The following is a description of a gene set: Genes containing one or more binding sites for (Nfatc1) in their promoter regions (TSS -1000,+100 bp) as identified by GTRD version 20.06 ChIP-seq harmonization. species: Mus musculus from publication Yevshin I, Sharipov R, Kolmykov S, Kondrakhin Y, Kolpakov F (PMID 30445619) Mouse Gene Set: NFATC1_TARGET_GENES, and this is the list of marker genes: Hsp90aa1, Gm5960, Rpl28-ps4, Xirp1, Exoc5, Gm8609, Kcnab1, Sars2, Stard3, Slc26a8, Or3a1c (olfactory receptor family 3 subfamily A member 1C), Plxna4os1, 1700095J12Rik, Pank4, Cyb561, Dynlt3, 4930428N03Rik, Gm15941, Hps1, Rbm5, Gm11349, Igkv3-10, Huwe1, Tspan31, Cwc22, Tmtc2, Necab3, Or7g19, 1600029O15Rik, L1cam, Exosc3, AU019990, Lrig3, S100a4, Gm28888, Npc1, Lrrtm2, Ndufb2, Sclt1, Opn1sw, Spata6l, Ppp1r42, Peg12 (paternally expressed 12), Gm19028, Xkr6, Gm17087, Gm37548, BC050972, Skint3, Gm17227, Foxj3, Mir16-2, 2900064K03Rik, Vgll1, Gm29741, Slc7a15, Dmkn, Sesn2, Slit2, Spart, Crlf1, Adgrl4, F830212C03Rik (RIKEN cDNA F830212C03 gene), Gm17501, Mir500, Pkn2, Gm11869, Gzmk (NCBI Gene Id 14945), Dcp1b, Hspa8, Pgk1, Or4b13, Gm12153, Sp1, Rbm46os, Arhgap12, Phldb2, Tanc1, Vps25, Aoc1l1, Gm23241, Ltbp3, Ascc3, Stxbp4, Pacrg, Tcf12, Gm12295, Zscan2, Gm24965, Slc38a6, Tns3, Akr7a5, Sntn, Lrfn5, Gm22576, Mustn1, Arf4, Gnas, Rpl37rt, Orai2, Serpinb10, Ppa1, Dnajc11, Avl9, Ifngr1, Ndrg3, Dctn6, Prss59, Ubqlnl, Cerk, Fnbp1l, Nr1i2, Cfap126, Nsun4, Hk1, Lce1c, Cp, A4galt, Col17a1 (collagen, type XVII, alpha 1), Cfap74, Gpc1, Cast, Dnajc13, Mapk14, 4931429P17Rik, Gm16508, Adam33, C6, Inhba, Tafa3, Cfap221, Rhpn2, Hmgb1, Spsb4, Plekhg4, Mgat4d, Sys1, Plcl1, Spmip3, Vat1l, Or6d12, Fam107b, Nr4a2, Ppie, Cyp2j11, Pramel6, Fbxo30, Gm25697, Lztfl1, Sap30, Or9g3, Ocm, Ceacam1, Nptn, Ccdc33, Gm14401, Mannr, 5830437K03Rik, Ica1, Snx25, Adcy6, Kdm1b, Slc26a3, Slc32a1, Acot12, Ppp1r12b, Atp2b4, Kntc1, Cdkn1c, Igsf9, Chn1, Ppp1cc, Spaca1, Nup42 (nucleoporin 42), Tiam2, Acadm, Srr, Slco1a5, Efcab6, Gm22985, Gtf3c3, Gm33866, Gm15564, Btnl9, Snrpn, Pes1, B530045E10Rik, St7, Bach2it1 (NCBI Gene Id 102635275), Primpol, 0610043K17Rik, Or13j1, Gm10163, Trim72, Kif3b, Arhgef2, B430319H21Rik, Apbb2, Gpr161, Phxr4, Nsd2, Card10 (NCBI Gene Id 105844), Mir5130, Ptges, 2500002B13Rik, Sec16b, Lmbr1l, A930006K02Rik, H1f8, B4gat1, Znhit1, Lix1l, Cdkn2d, Gm17057, Gramd2b, Slc25a21, Pprc1, Il1rap, Gm14679, Dennd1a, Plec, Zbtb7b, Slc2a13, Fxyd5, Toe1, Usp53 (NCBI Gene Id 99526), Nat3, Gls, Or5ar1, Gm17473, Aldh1l2, Cdh8, Kpna6, H2-Ob (histocompatibility 2, O region beta locus), Slc2a9, Gm22863, Usp38, Rad52, Tchp, Mir15b, Kifc3, Uhmk1 (NCBI Gene Id 98572), AU015336 (NCBI Gene Id 106309), Myo1c, Ankrd34b, Gjb4, Or4d10, Trpc4ap, Gm13219, Gm9632, Stk11, Cpvl, Furin, Dgkd, 4930551E15Rik, Becn1, 1700039E22Rik, Dstn, Ssc5d, I0C0044D17Rik, Mical2, Grid2ip, Gm2451, Lemd1, Ahcyl1, Gm15511, Ptprc, Abl2, Gm11392, Ctsl, Fscn1, Slc25a3, Gm28809, Nkx2-9, Chac1, Tlcd1, Gem, Ctbp2, Or2w1b, Pira2-ps1, Gm11862, Elavl4, Dars2, Ctdsp1, Plekha4, Frg2f1, Ctnna3 (NCBI Gene Id 73853), Vcan, Atf6, Arhgap19, Lep, Sec61bl, Lrp2bp, Retsat, Btn1a1, Hectd2, Gm7289 (NCBI Gene Id 640234), Pus10, Unc13b, Gnpat, Ep300, Gm11266, 2010003K11Rik, Cpa6, Sec14l1, Gsk3b, Serpinb3d, Mir6236, Mir467c, Cd82, Gm23691, Cep250, Ccdc9, Rnpc3, Glt8d2, Nudcd2, Ric1 (RAB6A GEF complex partner 1), Klhdc8b, Rab40c, Esp4 (exocrine gland secreted peptide 4), Gm32460, Hnrnpl, Mrps12, Or1o3, Rasgrp3, Cntn4, Gm19705, Smim43, Adamts6, Tnfaip2, Taf3, Arhgdib, Egfl7, Vps4b, Tmprss11b (NCBI Gene Id 319875), Gm28863, Pid1, Eif3d, Gm23644, Gm11816, Retreg1, Gm26080 (predicted gene, 26080), Gm17450 (NCBI Gene Id 115488131), Zup1, Neat1, Satb1, Mef2d, Fut1 (fucosyltransferase 1), Daw1, Igfbp4, Cep104, Scn1a, Nek8, Hikeshi (NCBI Gene Id 67669), 1700047M11Rik, Cdkn2c, Bnip1, Anxa11, Gm25384, Col24a1, Or1j16, Esrrb, Mpzl1, Ginm1, Gm12002, Syne2, Fmc1, Aig1, Gm12795, Meaf6, Plekhn1, Shc1 (NCBI Gene Id 20416), Tesc, Spata31g1, Gm14921, Cnn3, Acox1, Myocd, Mir6349, Slc39a13, Zfp286os, Gcnt2, Slc5a7, Dnhd1, Nsun7, Gm16084, Gm37358, Sorbs1, Cntrob, Ttyh3, Cttnbp2, Gm53065, Elmo1, Or4k6, Cenpl, Or4e1, Inpp5a, Ifitm2, Cc2d1b, Actl7a, E330020D12Rik, Srl, Gm5082, Gm25408, Frem1, Commd8, Mir652, Gm10222, Fchsd1, Pla2g7 (phospholipase A2, group VII (platelet-activating factor acetylhydrolase, plasma)), Gm43391 (NCBI Gene Id 115490167), Krtap19-3, Or6c76, Jph4, Esco1, Ltbp4, Pde4d, Dnm3os, 1700064H15Rik, Gal3st1, Gm28818, S100a5 (S100 calcium binding protein A5), 4930555A03Rik, Abi1, Ift74, 2310081O03Rik, Or5an6, Clca3a2, Ampd2, Gm5860, Cep85, Mdm4 (NCBI Gene Id 98570), Itga4, Gcg, Polr2a (NCBI Gene Id 20020), Bbs7, E230016M11Rik (NCBI Gene Id 320172), Lrrfip2, Eno4, Ttc9, Gm36953, Gm15824, Stxbp2, Gm19721, Polg2, Wscd2, Pitpnc1, Setd5, Dtnb, Gm23205, Rdh5, Gm14163, Or8b53, Entpd7, Eid2b, Ston2, Iglc2, Strbp, Nprl3, Cops6, Ech1, Paxbp1, Inpp5b, Gm12633, Nme1, Eya1, Dnah6, Gm26397, Srsf7 (serine and arginine-rich splicing factor 7), Grin2a, 1700041G16Rik, Med28, 4930449E01Rik, Pnrc1, Trim29 (NCBI Gene Id 76249), 1110065P20Rik, Larp1b, Izumo1, Nsun6, Pde7a, Znhit6, Sytl2, Ttll10, Heg1, Fblim1, Gm26101, Abcc2, Kctd12, 3300005D01Rik, Or8b12, Krt80, Vmn1r83, Sel1l, Ncbp1, Adap1, Pate12, Fancd2, Gm3294, Gfm2, 4921539E11Rik, Cpne3, Ndst4, Ubap2l, Trim16, Pcdha12, Itih1, Mir7653, Tpr, Gm24382, Gm22501, Katnal2, Gm10540, 4921504E06Rik, Etv4, Lgals1 (NCBI Gene Id 16852), Grem1, Ccn4, Ttc23, Mir874, Gm22268, Mir7002, Col9a1, Epb41l4b, Anxa8, Anp32a, Tnfsf14, Or10a3b, Nupr1, Zc2hc1a, Hnrnpc, Pnpla8, Smurf1, Eps8l2, Gtf3c5, Cd72, Bdnf, Gm7393, Raph1 (NCBI Gene Id 77300), Sult2b1, Slc66a3 (NCBI Gene Id 97797), Gm9929 (NCBI Gene Id 115487180), Ddx3x, Psmd11, Tpd52, Rpa2, Or7c74, Mtch2, Hoxa3, Abat, D930020B18Rik, Gbp2, Smt3h2-ps2, AW551984, Or1ad7-ps1, Rn7s6, Adamtsl4 (ADAMTS-like 4), Gm19175, Mcpt1, Ptprd, Gm19136, Cfap43, Safb, Duxf4, Nr1i3, Gm5342, Gm8343, Mcm10, Zfp658 (zinc finger protein 658), Galnt9, Ark2c, Cacna1h, Mtf2, Odf2, Krt6a, Rara, Camta2, Gm17224, Gm23124, Frmd8os, Nlrp9b, Pomt1, Gm13269, Zfyve27, Gm4735, 4930447N08Rik, Vmn2r-ps59, Mir7028, Gabra2 (NCBI Gene Id 78710), Gm17887, Acly, Ptgs2os, Prrc2c, Hypk, Osr2, Gm12711, Tnfaip3, Gm12134, Lrrc55, Gm17826, Evi2, Recql5, Ints13, Tbl3, Medag, Zfp444, Hmmr, Isy1, Swt1, Ptgs2, Lctl (NCBI Gene Id 235435), Itgad, Sumo2, Fancc, Preb, Ccdc136, Usp46, Brd7, Ywhag, Evi2a, Junos, Mthfs, Gm13729, Mbnl2, Akap6, Eps8l3, Odad4 (outer dynein arm complex subunit 4), Mir5110 (NCBI Gene Id 100628627), Gm11200, Serpinb11, Gm6522, Gm38051, Ubl3, Ivl, Gm11362, Urad, Cr2, Phrf1, Anapc1, Krtap2-4 (keratin associated protein 2-4), Kifbp (kinesin family binding protein), Tmem63b, 5430435K18Rik, Slc2a1, Trpm4, Zbtb20, Nr6a1, Pcgf3, Ablim1, Septin9, Tbc1d31, 1700041M19Rik, Gstt3, Gpr35, Gm26907, Depdc7, Tbx18, Trav5-1, Gm5302, Hrh4, Adamts4, Rpl21-ps13, Lce3a, Or8k3, Pigu, Adam5, Arhgef1, Wfdc15b, Itpkc, Ccdc121rt1, Mob4, Ccdc163, 1700028B04Rik, A430093F15Rik, D630024D03Rik, Fthl17f, Rbm43, n-R5s88, Prss42, Gm31651, A130023I24Rik, Pex1, Dynap, Csn1s2a, Ttn, Gm2539, Kbtbd7, Mir199a-2, Ppfia1, Erich2, Lnpk, Ccnd3, Cd9, Mmp16, Grk4, Zfp386, Slc39a14, Ap5m1, Ube2t, Commd1, Rheb, Plek, Rab3b, Plod3 (procollagen-lysine, 2-oxoglutarate 5-dioxygenase 3), Gm8357, Rpl29-ps2, Sfi1 (NCBI Gene Id 78887), Dhx58os, Ccdc50, Fbxo46, Mrgprf, Coro7 (NCBI Gene Id 78885), Gm15743, Nae1, Rwdd2a, A930018P22Rik, Scamp5, Chst15 (carbohydrate sulfotransferase 15), Agps, Yrdc (yrdC domain containing (E.coli)), Tppp3, Gm5444, Erc1, Slc1a2, Pramel46, Ctdspl2, Tigit, Gm23347, Sbds, Fam98b, Atg7, Gabarapl2, Alox12b, Spcs3, Col9a2, Anapc4 (anaphase promoting complex subunit 4), Ttc7, Dars1, Tmco4, Plch1, Slco4a1, Zfp329, Gm33969, Ankrd13c, Abcb9, Npl, Gm7731, Mir680-3, Foxm1, Tbcd, Arhgef26, Steap2, Snx33, Duxf1, Krtap1-5, Prelp, Gm26291, Ttc39d, Ccl7, Cspp1, Tbr1, 4930528D03Rik, Serpina10, Rapgef4os1, Nek5, Gm5269, Ggnbp2 (NCBI Gene Id 97681), Rpl27, Vmn2r127, Gm14279, Gm15565, Crybb3, Schip1, Ctnna2, Rbks, Acsl4, Ugdh, Carmil1, Dclre1c, Serpinb8, Hba-x, Actmap, Gga1, C1qtnf1, Gm13366, Gm37249, Phf21a, Lif (NCBI Gene Id 16878), Btn2a2, Garin1a, Gm11809, Wincr1, Cobl, Foxp1, Rad18, Slc4a2, 4930445N08Rik, Smg9, Cdrt4os1, Lrat, Ccdc62, Dync2i2, Gm23527, Cic, Rps19-ps10, 2310005A03Rik, 2010106C02Rik, Itm2b, Or4a74, Gm14153, Gm24223, Tnfrsf8, Dstyk, Blnk, Gm14280, Akr1c14, Mir139, Lbh, Zmynd8, Defb37, Fbxo43, Lrrc36, Zfp940 (NCBI Gene Id 233057), Capn5, Ehd4, Zg16, Gas7, Birc5, Banp, Bnc2, Hint3, Ces1e, Ahctf1, Arhgap35, Mrgprc2-ps, 4930511O05Rik, Pcsk2os2, Lmo7, Or1ad5-ps1, Ndufb6, Zfp949, Gm13869 (predicted gene 13869), Rbm6, Nrg1, Mir6369, 1700013A02Rik, Gm11498 (NCBI Gene Id 100417326), Adat1, Spag11a, 4930580E04Rik, Adamtsl2, Olfr363-ps, Spata31e2, 4930461G14Rik, Kcnk2, Nfkb1, Ank1, Ttc8, Akap9, Fmn1, Snw1, 4930562C15Rik, Prrg4, Col15a1, Rabgap1l, Gm22536, Mdga1, Fthl17a (NCBI Gene Id 71996), Gm23980, Samd4, Ccdc80, Mir7057, Sdccag8, Rcc1, Dnajc22, Gm13755, Slc66a1, Tenm3, Gm10155, Adsl